Given this list of marker genes ZNRF3, SFRP5, SFRP4, IFT80, RNF213 (ring finger protein 213), here is a description of the gene set: Any process that stops, prevents, or reduces the frequency, rate or extent of non-canonical Wnt signaling pathway. studied in species Homo sapiens Human Gene Set: GOBP_NEGATIVE_REGULATION_OF_NON_CANONICAL_WNT_SIGNALING_PATHWAY